The following is a description of a gene set: A heterodimeric protein complex that contains a serine protease inhibitor and a protease; formation of the complex inhibits serine protease activity. Human Gene Set: GOCC_SERINE_PROTEASE_INHIBITOR_COMPLEX species: Homo sapiens, and this is the list of marker genes: SERPINA5, KLK8, PLAT, PLAU, SERPINB6, SERPINE1